Given this list of marker genes TDRD1, APBA1, DDN, SORCS1, BCL9, CSNK1G3, PCYT1B, here is a description of the gene set: from publication Chen Y, Wang X (PMID 31504780) Human Gene Set: MIR5739 studied in species Homo sapiens Genes predicted to be targets of miRBase v22 microRNA hsa-miR-5739 in miRDB v6.0 with MirTarget v4 prediction scores > 80 (high confidence targets).